The following is a description of a gene set: TLR2 and TLR4 recognize different bacterial cell wall components. While TLR4 is trained onto Gram-negative lipopolysaccharide components, TLR2 - in combination with TLR6 - plays a major role in recognizing peptidoglycan wall products from Gram-positive bacteria, as well as Mycobacterial diacylated lipopeptides. In particular, TLR6 appears to participate in discriminating the subtle differences between dipalmitoyl and tripalmitoyl cysteinyl residues. studied in species Homo sapiens part of: Toll Like Receptor 2 (TLR2) Cascade Reactome Pathway: Toll Like Receptor TLR6:TLR2 Cascade, and this is the list of marker genes: MAP2K1, NFKBIA, VRK3, TAB3, TP53, MAP2K7, PELI3, NOD1, JUN (Jun proto-oncogene, AP-1 transcription factor subunit), BTRC, APP, MAPK14, PELI2, MAP3K7, CD36, TNIP2, IRAK1, MAPKAPK2, TRAF6, FBXW11, DUSP7, UBC, MAP2K4, NKIRAS2, N, FGG (fibrinogen gamma chain), MAPK11, porB, TLR6, UBE2N, S100A1, HMGB1, TLR4, MAPK3, CASP8, MAPK1, MAPK9, NOD2, S100B, RPS6KA1, SOCS1, FOS, MAPKAPK3, IKBIP, LY96, TRAF2 (TNF receptor associated factor 2, NCBI Gene Id 7186), DUSP6, MYD88, NFKB2, MAPK10, FGA, MAPK7, IRAK2, MAP3K1, ELK1, NKIRAS1, PPP2R1B, PPP2R1A, FGB, UBA52, S100A12, MEF2A, LRRC14, CHUK, USP14, MAP2K3, IRAK4, PPP2R5D, IKBKG, RPS6KA5, UBB, DUSP3, S100A9, CUL1, mip, PPP2CB, NLRC5, MAPK8, TAB1, BTK, ECSIT, SAA1, CREB1, CD14, TIRAP, TLR2, DUSP4, RPS27A, TIFA, AGER, PPP2CA, NLRX1, RELA, UBE2V1, PELI1 (NCBI Gene Id 57334), MEF2C, N4BP1, RIPK2, ATF2, RPS6KA2, MAP2K6, RPS6KA3, NFKB1, S100A8, TLR1, NFKBIB, MAP3K8, SIGIRR, SKP1, TAB2, IRAK3, ALPK1, IKBKB, ATF1, USP18